Given this list of marker genes KRT19P2, ENSG00000257283, CLLU1, PGAM1P5, CRADD, ENSG00000308842, LINC02397, VEZT (vezatin, adherens junctions transmembrane protein), CEP83, LNCHR1, RN7SKP263, CBX3P5 (NCBI Gene Id 100421943), ENSG00000201502, RNU6-247P, ENSG00000302422, LSM3P2, RBMS2P1, NDUFA12, LINC02412, MTCH2P2, NTN4, HNRNPA1P50, RN7SL330P, ENSG00000293398, RNU6-1329P, PLXNC1, MIR3685, CRADD-AS1, FGD6, SOCS2-AS1, ENSG00000257746, RPL29P26, LINC02410, RNU6-735P, CEP83-DT, SUCLG2P2, MIR7844, NACAP8, UBE2N, NR2C1, MRPL42, RNU6-808P, TMCC3, CLLU1-AS1, RPL41P5, EEA1, MIR331, METAP2, LINC02413, SOCS2, PLEKHG7, NUDT4, DPPA3P5, USP44, ENSG00000298833, RN7SL737P, NSA2P2, MIR492, RN7SL630P, LINC02391, RN7SL483P (RNA, 7SL, cytoplasmic 483, pseudogene), MIR5700, here is a description of the gene set: Human Gene Set: chr12q22 species: Homo sapiens